The following is a description of a gene set: Mouse Gene Set: GOBP_NEGATIVE_REGULATION_OF_TYPE_2_IMMUNE_RESPONSE Any process that stops, prevents, or reduces the frequency, rate, or extent of a type 2 immune response. studied in species Mus musculus, and this is the list of marker genes: Zfp35, Ifnb1, Stat6, Irf1, Anxa1, Ascl2, Arg2, Tbx21, Socs5, Il27ra, Hlx, Bcl6, Ndfip1, Arg1, Ccr2